Given this list of marker genes SLK, CAVIN1, MCF2, ARHGAP39, ARHGEF25, ARHGAP5, ARHGAP35, RHOC, MYO9B, TMPO, ARHGAP32, ERBIN, FLOT1, TJP2, BCR, ARHGDIA, ARHGEF10L, ACBD5, ARHGEF10, LBR, CCDC187, ANLN, FMNL2, VAV2, STARD13, PKN2, VAPB, TFRC, PIK3R1, DEPDC1B, MCF2L, OPHN1, STK10, ARHGAP26, MACO1, ARHGEF40, ARHGEF17, FLOT2, AKAP13, DIAPH1, LMAN1, VAMP3, ARHGEF28, STOM (NCBI Gene Id 2040), MCAM, ARHGAP1, ABR, PREX1, IQGAP1, JUP, RACGAP1, ROCK1, ARHGEF12, DIAPH3, ARHGEF11, C1QBP, CIT, ABCD3 (NCBI Gene Id 5825), RHOA, IQGAP3, ARHGAP21, FMNL3, PKN3, VANGL1, DLC1, PKN1, RTKN, ROCK2, ARHGAP18, ARHGEF1, DAAM1, ARHGEF5, CAV1, STX5, here is a description of the gene set: studied in species Homo sapiens Human Gene Set: REACTOME_RHOC_GTPASE_CYCLE RHOC GTPase cycle